The following is a description of a gene set: Binding to a keratin filament, an intermediate filament composed of acidic and basic keratins (types I and II), typically expressed in epithelial cells. Mouse Gene Set: GOMF_KERATIN_FILAMENT_BINDING species: Mus musculus, and this is the list of marker genes: Sirt1, Krt74, Krt14, Flg, Fam83h, Vim, Eppk1